The following is a description of a gene set: Activation of BAD and translocation to mitochondria studied in species Homo sapiens Human Gene Set: REACTOME_ACTIVATION_OF_BAD_AND_TRANSLOCATION_TO_MITOCHONDRIA, and this is the list of marker genes: BAD, YWHAB, AKT2, AKT1, YWHAZ, AKT3, YWHAQ, SFN, PPP3CC (protein phosphatase 3 catalytic subunit gamma), BCL2, YWHAH, PPP3R1, YWHAG, YWHAE, BID